Given this list of marker genes NUP160, CD69, CD52, LTV1, GATD1-DT, HYCC1, LPXN, RALY-AS1, DCAKD, SH3KBP1, ZNF462 (zinc finger protein 462), DIAPH3, PIP4K2A, CLOCK, IL10RA, ZNF142, CYTIP, RPL39L, DIPK1B, SPATC1L, TMEM183A, TET1, L3MBTL3, CLCA2, MCUR1, PHTF2, ISYNA1, ARRDC2, DNAJC4, IRGQ, PEX11A, CCDC15, PWWP2A, TRAF1, C19orf48P, FABP3, CRTC1, NUP35, GPC1, SHLD2, MFSD3, GAS2L1, NDRG4, MBNL3, PPP1R9B, RNF166, ACSF3, TCF7, SLC2A3, RBSN, CDIP1, GAS7, LAPTM5, here is a description of the gene set: species: Homo sapiens Human Gene Set: GAO_ESOPHAGUS_25W_C3_FGFR1LOW_EPITHELIAL_CELLS from publication Gao S, Yan L, Wang R, Li J, Yong J, Zhou X, Wei Y, Wu X, Wang X, Fan X, Yan J, Zhi X, Gao Y, Guo H, Jin X, Wang W, Mao Y, Wang F, Wen L, Fu W, Ge H, Qiao J, Tang F (PMID 29802404)